Given this list of marker genes STAMBP, FGF10, PPP2CB, NUP62, MAPKAP1, RABL3, NF1, EPHB2, RASA4B, SPRY3, RASA2, STK19, RASGRF1, SQSTM1, DAB2IP, SPRY1, FBP1, MFN2, IGF1, RASAL3, SPRY2, FOXM1, RABGEF1, RASA3, NOTCH1, SYDE1, NTRK1, KITLG, TGFB2, SYNGAP1, RASGEF1A, NGF, RASA4, NOTCH2, SYDE2, TRIM67, RASGRP1, LZTR1, CSF1, MAP2K1, EPO, FLCN, SPRY4, MMD2, SHOC2, ITPKB, PICALM, RASAL1, here is a description of the gene set: species: Homo sapiens Human Gene Set: GOBP_REGULATION_OF_RAS_PROTEIN_SIGNAL_TRANSDUCTION Any process that modulates the frequency, rate or extent of Ras protein signal transduction.